The following is a description of a gene set: The chemical reactions and pathways resulting in the breakdown of cyclic GMP, guanosine 3',5'-phosphate. studied in species Homo sapiens Human Gene Set: GOBP_CGMP_CATABOLIC_PROCESS, and this is the list of marker genes: PDE10A (phosphodiesterase 10A), PDE9A, PDE1A, PDE5A, PDE2A